Given this list of marker genes Pex2, Pex16, Pex1, Pex13, Pex10, Pex3, Pex7, Pex19, Pex6, Hacl1, Trim37, Zfand6, Usp9x, Pex26, Pex12, Pex14, Rab8b, Pex5, Lonp2 (lon peptidase 2, peroxisomal), Pex5l, here is a description of the gene set: species: Mus musculus The directed movement of a protein to a specific location in a peroxisome. Mouse Gene Set: GOBP_ESTABLISHMENT_OF_PROTEIN_LOCALIZATION_TO_PEROXISOME